Given this list of marker genes ADAR, LRP5, NUP54, CNGB3, NUP62, MT-ATP6 (NCBI Gene Id 4508), ARHGEF2, TMEM106B, here is a description of the gene set: species: Homo sapiens Horizontal pendular nystagmus Human Gene Set: HP_HORIZONTAL_PENDULAR_NYSTAGMUS Nystagmus consisting of horizontal to-and-fro eye movements of equal velocity.